Given this list of marker genes Cttnbp2, Npy, Lmo3, Serpini1, Adamts20, Casz1, Tmem68, Epc2, Grm3, Nceh1, Dnajb12, Cab39, Hopx, Erbb4, Fam76b, Spryd7, Htr5a, Zfp606, Phf6, Ptch2, Chd1, Ccn3, Csmd1, Zfyve21, Dmtf1, Zbtb14, Topbp1, Eid2, Nom1, Plac9, Dpp6, Fat3, Foxa1, Usp42, Ccdc166, Unk, Stam2, Wnt5a (wingless-type MMTV integration site family, member 5A), Pgm2l1, Lmbr1, Rb1cc1, Snca, Nptn, Fzd8 (frizzled class receptor 8), Rnf4, Bche, Fndc3b, Tet1, Dach1, Zfp608, Dbx1, Ptprr, Dagla, Sox6, Mfsd2a, Cacna1c, Cav2, Prkacb, Syvn1, Pafah1b2, Slc1a2, Trp53inp1, Pik3c2a, Epc1, Stx12, Atad1, Ap1b1, Ppp2cb, Cxcl16, Ccna2, Ppp1r26, Nusap1, Zfp354c, Arid5b, Nlgn1, Evi2b, Ing3, Vegfa, Gnb4, Lzts2, Dpm1, Trh (NCBI Gene Id 22044), Sos1, Spag9, Nek1, Rpain, Nexmif, Igfbp1, Tbc1d15, Ncald, Klf4, Cysltr1, Prkce, Wipf3, Adamts17 (ADAM metallopeptidase with thrombospondin type 1 motif 17), 1110059E24Rik, Fgf4, Chmp4c, Hoxd1, Psd3, Ahdc1, Insm2, Fbxo33, Ikzf2, Arid1a, Vezf1, AI182371, Steep1, Gabra2, Pum2, Tcf7l2, Lgr4, Prkg2, Efna5 (NCBI Gene Id 13640), Crebzf, Itm2c, Foxc1, Gpr183, Crx, Orc1, Syngr3, Zswim6, Foxj2, Col5a1, Ccdc102a, Irx1, Cbfb, Rasal2, Arl8a (ADP-ribosylation factor-like 8A), Chic1, Hsf2, Tfb1m, Mob4, Stard13, Map4, Zfp236, Srek1ip1, Vmp1, Ensa, Trappc6b, Smad9, Jrkl, Tmc8, Avl9, Vps13d, Hat1, Utp18, Ednra, Crybg3, Anks1b, Gucy1a2, Ppm1h, Rbm25, Grk5, Bcl2l11, Sv2b, Vwc2l, Stxbp5l, Nectin4, Pik3ca, Msi2, Ccr2, Zfp518a, Zcchc24, Nr3c1, Ccnc, Vps33b, Crim1, Rabggtb, Myct1, Oprk1, Cggbp1, Zc2hc1a, Ube2w, Cnot6l, Nopchap1, Tmem196, Bmper, Zmym2, Irx3 (NCBI Gene Id 16373), Arhgap29, Ptpre, Vcan, Ctdspl2, Spry1, Dock3, Adam22, Jcad, Ank3, Snx14, Adgrg2, Robo2, Optn, Efr3b, Nfkbia, Inpp5b, F3, Twist2, Zfp148, Ccdc185, Brcc3, Ash1l, Arhgap12, Lrrc42, Eri1, Hs6st2, Foxo1, Gpkow, Dek, Dapk1, Bnc1, Usp7, Wsb1, Pitpnb, Btaf1, Cep192, Tnrc6b (NCBI Gene Id 72625), Prkaa1, Tgfbr1, Zbtb22, Magoh, Tmem178, Vstm4, Asap1, Nr5a2, Pdik1l, Camk2d, Cilk1, Fut9, Man1a2, Cnot2, Arhgef10l, Rab2a, Lipg, Golga2, Denr, Vcf2 (NCBI Gene Id 76170), Plxna2, Hecw2, Adarb1, Foxq1, D630023F18Rik, Psma3, Cadm1, Uty, Plag1, Gas1, Pcdh11x, Sp100, Galr1, Marchf5, Nup35, Naa15, Dmxl1, Fnip1, Sema3d, Acp2, Hbp1, Arid4b, Iars2, Rcan2, Smoc1, Atl2, Carmil1, Capn1, Itfg1, Zfp248, Bcl11b, Paip1, Vcam1, 9330159F19Rik (NCBI Gene Id 628860), Hnrnpr, Zxdb, Clip1, Dll1, Fhip2a, Cldn17, Pou3f2, Stard8, Diaph2, Dnajc6, Tmed7, Oga, Gtpbp2, Ric3, Mbnl1, Hmgxb4, Iqca1 (NCBI Gene Id 75891), Thrb, Lats1, Vps26a, Syncrip, Asic4, Adam9, Ptpra, Itch, Ccdc126, Slc38a2, Glcci1, Cspp1, Ccar2, Pcsk2, Pkd1, Lcorl, Ifngr1, Rasgef1a, Sorcs3, Cry1 (NCBI Gene Id 12952), Hectd1, Cxadr, Nr1h5 (NCBI Gene Id 381463), Eps8, Cds2, Mamdc2, Mrpl39, Homer1, Mzt1, Spred1, Taf4b, Simc1, Kbtbd2, Kcnh5, Calhm5, Exosc7, Ppp1r14c, Xrn2, Cbx5, Bnip2, Rab8b, Abca8a, Dennd2b, Gpcpd1, Ndnf, Nufip2, Ndel1, Naaladl2, Cntrob, Usp31, Gm527, Plekhg5, Cic, Kif3a, Irx5, Fgd4, Col19a1, Pafah1b1, Cnnm4, Spc25, Tm4sf4, Cks2, Nedd4l, Nemf, Jph1, Pdgfra, Mphosph9, Kdm3a, Sncaip, Herc2, Camsap2, Aqr, Rnf24, 5730455P16Rik, Kcna2, Rab11fip1, Ssbp2, Pou4f2, Zbtb10, Sestd1, Scamp2 (NCBI Gene Id 24044), Atp2b4, Sfrp2, Sbf2, Zc3h7b, Brd3, Slc39a10, Rasef, Dlc1, Fgf12, Scai, Hmcn1, Mrtfa, Tubgcp5, Tmem33, Irf2bp1, Sik1, Pcf11, Mbd5, Rab18, Cacnb2, Arap2, Ankrd1, Tafa1, Lamtor5, Dlx4, Ing1, Ttc8, Cldn23, Prkcd, Nkx2-9, Adamts1, Mycbp2, Bbx, Ptp4a1, Tspan2, Spink5, Rbbp9, Scn2a, Btnl9, Ppm1k, Rgmb, Rab3gap2, Ppp1r15b (protein phosphatase 1, regulatory subunit 15B), Casd1, Tbc1d4, Myf5, Rock2, Klf12, Dnm2, Nodal (nodal growth differentiation factor), Car10, Tbx18, Pip5k1b, Snrk, Strn3 (NCBI Gene Id 94186), Gabrb3, Slc30a4, Adamts5, Hivep1, Nfyb, Pgr, Tab3, Gdap2, Zc3h12c, Cdc42ep3, Mef2c, Nup133 (NCBI Gene Id 234865), Plekhg1, Daam1, Cobll1, Pik3r1, Zfp280d, Zic1, Loxl3, Myorg, Phactr4, Fbxl17, Suv39h1, Aebp2, Dcun1d3, Antxr1, Efcab14, Sox9, Pcdh8, Clspn, Ddx60, Plcb1, Irs1, Ints6, Zfx, Rab3c, Ugcg (NCBI Gene Id 97164), Ubap2l, Penk, Arl14epl, Golt1a, Carf, Trim63, Grm5, Cbln4, Tbr1, Cecr2, Gm5592, Zmym3, Pclo, Erlec1, Dcun1d4, Nsd1, Adgrl2, Dll4, Baz2b, Fa2h, Alg1, Adck1, Cyth3, Ralyl, Nog, Acr, Slc6a19, Cadm2, Rai1, Hoxa9, Mcl1, Marchf6, Dnm3, Otud4, Kdm6a (lysine (K)-specific demethylase 6A), Gm15881, Itga4, Tmem236, Plch1, Gstt3 (NCBI Gene Id 103140), Yy1, Rras (NCBI Gene Id 20130), Twist1, Ythdc2, Susd6, Mbd2, Camk1d, Ogfrl1, Ctdsp1, Sms (spermine synthase), Nphp3, Prpf4b, Tanc2, Ism1, Stk17b, Cd200r1, Erich1, Terb2 (telomere repeat binding bouquet formation protein 2), Lmo1, Fbxo30, Morf4l2, Tiam1, Creld2, Bmp5, Bmpr1b, 1810062G17Rik, Lypd1, Apobec3, Phf12, Pias1, Fam174a, Tcf12, Usp6nl, Syt1 (NCBI Gene Id 20979), Grk6, Cyp26b1, Akap9, Hes1, Slc28a3 (NCBI Gene Id 64079), Pmp22, Btbd7, Lef1, Zfp715, Slc30a10, Btf3l4, Etaa1, Rnf38, Lin28a, Psmd5, Pter, Fam199x, Adgrb3, Zcchc8, Slc34a2, Cflar, Slc20a2, Lemd3, Tmem161b, Pitx2, Kif23, Fam43a, Ano1, Akap6, Slc7a1, Ss18l1, Hhip, Aftph, Bri3bp, Evx2, Acvr2b, Usp12, Ppp2r5e, Kit, Xrcc2, Foxj3, Tmprss11b, Fbxo45, Prickle1 (prickle planar cell polarity protein 1), Brd1, Prkar1a, Zc3h4, Mtor, Rassf5, Cpne3, Amotl2, Ttc7, Mysm1, Glis1, Atad5, Nsmce4a, Pum1, Wdr44, Usp29, Arl6ip6, Trpc1, Sh3rf1, Spry2, Gtf2b, Arpp21 (cyclic AMP-regulated phosphoprotein, 21), Mycn, Zbtb44, Slc6a8, Prdm16, Tek, Tet2, Ppp1r21, Hnf4g, Sox21, Grb2, Emp2, Ino80d, Camta1, Zfp93, Rab6b, Epha5, Necap1, Ifrd1, Dclk2, Arhgap6, Id1, Sez6l, Adcyap1, Fech, Slc8a1, Ppat, Myf6, Pdzrn3, Klf15 (Kruppel-like transcription factor 15), Slc25a16, Wnt3, Mef2a, Igf2r, Pappa, Whamm, Mast4, Met, Jag1, Srgap3, Ripply2, Slc4a7, Stat3, Zfp182, Sstr1, Slc5a1, Stk24 (NCBI Gene Id 69763), Dsc1, Lin54, Ncf1, Hnrnpdl, Arih1, Sstr2, Raph1, Col25a1, AW554918, Mitf, Ets2, Rbm39, Slmap, Msantd2, Rsrp1, Il1rap, Dock1, Arhgap44, Mab21l1, Tut4, Trhr, Slc30a5, Znrf3, Il18rap (NCBI Gene Id 16174), Mbnl3, Gopc, Cdk19, Zic3, Traf3ip1, Fam171a1, Tmprss11e, St8sia4, Cntfr, Mtf2, Slitrk6, Zbtb7a, Fnbp4, Kif11, Ctr9, Ncoa2, Bltp1, Rif1, Crebrf, Inpp4a, Zfp518b, Taok1, Hexim1, Opa1, Mtmr6, Ppp1r7, Pten, Kmt2c (NCBI Gene Id 384164), Meox2, Leprotl1, Zfp292, Gabrb2, Kics2, Tspoap1, Tec, Mosmo, Timm10, Wee1, Nkx2-1, Slc35a3, Map3k8, Grhl3, Pdap1, Mbtd1, Ice1, Manea, Klf2, Mex3c, Bdnf, Sun1, Rbm27, Fgfr2, Tshz3, Zfp831, Cxcl5 (C-X-C motif chemokine ligand 5), Nfat5, Nedd9, Trib1, Nbea, Hivep2, Itga2, Or52n4, Paxbp1, Foxd4 (NCBI Gene Id 14237), Ptbp3, Abi1, Adamtsl3, Edem3, Hook3, Rab11fip2, Rabgap1, Ccnb1, Cdc14a, Thbs2, Xiap, Cdkn1b, Far1, Asf1a, Arhgef7, Slc38a1, 1110059G10Rik, Impact, Akap12, Rfx8, Slc7a11, Slc23a2, Zbtb49, Gsk3b, Sos2 (SOS Ras/Rho guanine nucleotide exchange factor 2, NCBI Gene Id 20663), Zfp131, Stx7, Abca14 (ATP-binding cassette, sub-family A member 14), Kif20b, Spindoc, Nktr, Eda, Rbm5, Prdm1, Rasgrf1 (RAS protein-specific guanine nucleotide-releasing factor 1), Tm9sf3, Ttll7, Tspan12, Med6, Col11a1 (collagen, type XI, alpha 1), Malt1, Ercc3, Eml6, Dleu7, Myo5b, Cdr2, Extl3, Rbl1, Esrrg, Zc3h11a, Snx12, Rgs4, Fbxo43, here is a description of the gene set: studied in species Mus musculus Genes predicted to be targets of miRBase v22 microRNA mmu_miR_669b_3p in miRDB v6.0 with MirTarget v4 prediction scores > 80 (high confidence targets). from publication Chen Y, Wang X (PMID 31504780) Mouse Gene Set: MIR_669B_3P